Given this list of marker genes Morc3, Ubd, Zbtb18, Parp2, Sectm1a, Sp140, Scaf1, Psme1, Acod1, Nbeal2, Rab8a, Cxcl10, Tbx21, Pik3r5, Ermard, Trim14 (NCBI Gene Id 74735), Sik3, Cxcr6, Lmf2, Ifng, Slc15a4, Kcnj10, Nkg7, Gimap3, Itgb7, Gimap4, Cd3e, B2m, Ccl3, Serpina1a, Inpp5b, Calm3, Arhgef2, Ppp1r21, Pomp, Itgb2, Tmem106a, Ptpa, Gbp4, Irf8, G6pd2, Il2rb, Rnf34, Vps54, Sipa1, Batf2 (basic leucine zipper transcription factor, ATF-like 2), Vasp, Ly6c1, Iigp1, Cmtr1, Csl, Pip4k2a, Hmga1b, Arf2, Igtp, Zfp276, H2-DMa, Ube2l6, Ifi44l, Gca, H2-Q10, Cnot8, Ik, Zbtb32, Zfp691, Atp6v0a2, Aoah, Tceanc2, Ptpn22, Klra5, Stat1, H2-M3, Gbp3, Klrd1, Slc28a2b, Slc11a1, Samd4b, Sh3bp1, Erlin1, Cst7, Tle5, Rnf13, Gzmb (granzyme B), Havcr2, Phf11b, Gnpda1, Prf1, Oasl1, Skap1, Hck, Serpina3f, B4galt5, Gga3, Cpne2, Upp1, Zbp1, Espl1, Nlrc5, Cd247, Snx5, Sdc3, Srprb, Riok3, Nrm, Ccl4, Slc16a10, Gbp5, Cd300ld2, Relb, BC048507, Pank2, Il21r, Ifi47, Trex1, Irf5, Cenpj, Stat6, Slc25a25, Slfn1, Tank, Max, Ifit3, Cd300ld3, Irgm1, Axin1, Vrk2, Tnfrsf1a, Cybb, Ppp6r1, Cd74 (NCBI Gene Id 16149), Rela, Cd274, Nadk, Mark2, Wasf2, Pip4p1, Cxcl13, Cfb, Fermt3, Spn, Ltb, Serpina3g, Mapk14 (NCBI Gene Id 26416), Ly9, Zfp513, Git2, Lrp10, Lrch4, Aftph, Donson, Klk4, Nbdy, Csk, Tapbpl, Naa60, Rfc5, Klra10, Slamf8, Ly6c2, Pxn, Il12rb2, Calhm6, Zap70, Sh2b3, Slc28a2, Il27, Ebi3, Slc15a3, Sp110, Eif4enif1, Themis2, Emp3, Tgtp2, Cry1, Cd8b1, Cherp, Psmb9, Clec12a, Ccl2, Scimp, Gnai2, Mapre2, Ctsw, Il12rb1, Hk3, Gimap7, Irf1, Kbtbd11 (kelch repeat and BTB (POZ) domain containing 11), Fgl2, Ccrl2, Gzma, Aldoart2, Mid1, Babam1, Ciao3, Il18bp, Irak1, Vav2, Sec24b, Klrc1, here is a description of the gene set: Most patients with cancer are refractory to immune checkpoint blockade (ICB) therapy, and proper patient stratification remains an open question. Primary patient data suffer from high heterogeneity, low accessibility, and lack of proper controls. In contrast, syngeneic mouse tumor models enable controlled experiments with ICB treatments. Using transcriptomic and experimental variables from >700 ICB-treated/control syngeneic mouse tumors, developed a machine learning framework to model tumor immunity and identify factors influencing ICB response. Projected on human immunotherapy trial data, found that the model can predict clinical ICB response. further applied the model to predicting ICB-responsive/resistant cancer types in The Cancer Genome Atlas, which agreed well with existing clinical reports. Metagene derived from the post-Immune checkpoint blockade treated samples. Significance of the post-ICB sample metagenes was not discussed in the study. Mouse Gene Set: ZENG_GU_POST_ICB_METAGENE_31 from publication Zeng Z, Gu SS, Wong CJ, Yang L, Ouardaoui N, Li D, Zhang W, Brown M, Liu XS (PMID 36240281) species: Mus musculus